The following is a description of a gene set: from publication Cui A, Huang T, Li S, Ma A, Pérez JL, Sander C, Keskin DB, Wu CJ, Fraenkel E, Hacohen N (PMID 38057668) Mouse Gene Set: CUI_CDC2_OSM_RESPONSE_DN species: Mus musculus Genes negatively differentially expressed in cell type: cDC2 (conventional dendritic cell type 2) upon treatment with cytokine: OSM in mouse lymph nodes in vivo. Cytokines mediate cell-cell communication in the immune system and represent important therapeutic targets. A myriad of studies have highlighted their central role in immune function, yet we lack a global view of the cellular responses of each immune cell type to each cytokine. To address this gap, the authors created the Immune Dictionary, a compendium of single-cell transcriptomic profiles of more than 17 immune cell types in response to each of 86 cytokines (>1,400 cytokine-cell type combinations) in mouse lymph nodes in vivo. A cytokine-centric view of the dictionary revealed that most cytokines induce highly cell-type-specific responses. For example, the inflammatory cytokine interleukin-1β induces distinct gene programmes in almost every cell type. A cell-type-centric view of the dictionary identified more than 66 cytokine-driven cellular polarization states across immune cell types, including previously uncharacterized states such as an interleukin-18-induced polyfunctional natural killer cell state., and this is the list of marker genes: Arl5c, Nadk, Klf4, Klf6, Zeb2, Ier2, Btg2, Cybb, St8sia6, Zfp36, Itm2b, Asap1, Fosb, Atf3, Btg1, Hspa1a, Fos, Zfp36l1, Ccrl2, Rhob, Cd180, Nr4a1, Ncf1, Mcemp1, Foxp1, Rel, Bri3, Jun, Tmcc1, Mbnl1, Pmaip1, Jund, Neat1, Eif3e, Nfkbiz, Lmo4, Ppp1r15a, Nr4a2, Klf2, Junb